The following is a description of a gene set: Active immunotherapy is a promising strategy for anti-angiogenic cancer therapy. Recently, we have reported that a vaccine using human umbilical vein endothelial cells (HUVECs) induced specific anti-endothelial immune responses in the most of immunized patients, and resulted in tumor regression in some patients with recurrent malignant brain tumors, whereas not in colorectal cancer patients. In this study, we hypothesized that non-hypoxic perivascular tumor associated macrophages (TAMs) in colorectal cancer, but not in glioblastoma, might negatively alter the therapeutic efficacy of anti-angiogenic active immunotherapy. To test this hypothesis, we examined global gene expression profiles of non-hypoxic macrophages stimulated in vitro by soluble factors released from tumor cells of human glioblastoma U-87MG (‘brain TAMs’) or colorectal adenocarcinoma HT-29 (‘colon TAMs’). Genes down-regulated in tumor associated macrophages conditioned by: glioblastoma versus colorectal adenocarcinoma. Human Gene Set: GSE18804_BRAIN_VS_COLON_TUMORAL_MACROPHAGE_DN species: Homo sapiens, and this is the list of marker genes: SGO2, PLN, ZFPM2, CHN1, SUGT1P3, KRT79, TOP1MT, MED20, CCM2, ZNF775, STAT6 (signal transducer and activator of transcription 6), SULT1A2, ARFGEF1, FSHR, LUM, PTPN4, ZNF696, RIDA, LINC03124, ENAH, PSMD1, NAALADL1, FKBP7, TRAM1, NUDCD1, PDE7A, EBAG9, DYNLL2, CADM3-AS1, ICA1, MRPL15, CLEC4E, PURPL, RPL30, VPS28, CDK5R2, TMEM177, NDUFAF6, XRCC5, TWF1, DCAF13, RBP7, ELOC, NIPAL2, TCEA1 (NCBI Gene Id 7865), BOLA1, EEF1B2, ATP6V1H, NIF3L1, ANKRD53, LIF-AS2 (NCBI Gene Id 91370), CHCHD7, NBN, GRIN3B (NCBI Gene Id 116444), INPP1, MCUR1, JAZF1, RPL8, SLC39A4, HOXA10, GFUS, MRPL13, CPNE3, HOXA11-AS, PPP1R3B, E2F5, ZNF366, ADAM9, EIF3H, IFT172, CCDC157, GCAT, SH2D1B, INSRR, GABRG1, BAG2, MTHFD1, STPG2, SAP130, FDPS, EFEMP1, NCL, COPS5, HSPA1A (NCBI Gene Id 3303), HESX1, CACYBP, GPC3, GMFB, SLC35D2, GTF3C6, UBR5, GAL, WASHC5, PLIN2, IL24, HDDC2, MMAB, CRYBA2, GSTP1, BZW2, SCRIB, TACR1, EEF1D, CHMP4C, ATIC, ITPRID2, FABP5, INTS10, TRIB1, SLC1A1, KHDRBS2, NDUFS1, CTHRC1, ARHGEF10, LGALS3, SLC25A32, PHF19, BZW1, HOXD13, TRMT12, RPP40 (NCBI Gene Id 10799), VSX1, PINX1, PHF20L1, PLAGL1, NIN, IMPA1, C11orf52, HOXA5, PDLIM2, RNF139, CD274, HOXA9, PABPC3, PRKRA (NCBI Gene Id 94716), TRIP12, RBM45, IFI16, LAMA2, PBX3, INTS8, ECI1, LINC01116, SNTB1, REV3L, PEX26, NAPRT, FOLH1 (NCBI Gene Id 93212), CA2, AVEN, TGS1, THBS4, TUSC1, ASAP1 (NCBI Gene Id 56237), COMMD5, CYBRD1, TMEM64, CST7, IGSF5, PPM1A, ZFHX4 (NCBI Gene Id 79776), STK3, RBM3, GPR171, ATAD2, NSMAF, PABPC1, MRPS28, YWHAZ, DUXAP10, MAIP1, TRIM38, SDCBP, NAA30, PITPNB, CD84, METTL8, SYBU, NRXN3, LSM1, OPRK1, CCT6A, OSMR, RAB26, DSCC1, FBXO25, ATPAF2, C8orf76, FAM91A1, NSMCE2 (NSE2 (MMS21) homolog, SMC5-SMC6 complex SUMO ligase), ACTR10, RDH10, RAD21, PCDH20